Given this list of marker genes Fgfr3, Hes5 (hes family bHLH transcription factor 5), Adgrv1 (adhesion G protein-coupled receptor V1), Bmp4, Strc, Gfi1, Cdh23, Grxcr1, Pjvk, Whrn, Alg10b, Ush1c, Pafah1b1, Ntrk2, Atoh1, Gabrb3, Jag1, Elmod3, Hes1, Trip11, Triobp, Rbpj, Pcdh15, Gabrb2, Atp8b1, Grxcr2, Rac1, Atp2b2, Tecta, Tsku, Minar2 (membrane integral NOTCH2 associated receptor 2), Myo6, Ntf5, Cux1, Mycn, Kif3a, Fgfr1, Clrn1, Lhfpl5, Hey2, Kcnq1, Pls1, Dll1, Mcoln3, Clic5, Ptprq, Fzd2, Nherf1, Slc4a7, Cthrc1, Fat4, Otog, Sec24b, Esrp1, Ift27, Sdc4, Cecr2, Ripor2, Ntrk3, Mks1 (NCBI Gene Id 380718), Dicer1, Fgf2, Slc44a4, Tprn, Ift20, Ift88, Scrib, Ush2a, Gabra5, Slitrk6, Mycl, Ttc8, Tmem132e, Fgf20, Wdpcp, Notch1, Kcnma1, Naglu, Alms1, Gsdme, Sod1, Ntf3, Myo3a, Pou4f3, Rest, Myo7a, Tomt, Clrn2, Hey1 (NCBI Gene Id 99610), Pdzd7, Vangl2, Ankrd24, Mir96, Myo3b, Jag2, Ntrk1, Bdnf, Tmc1 (NCBI Gene Id 74462), Diaph3, Tshr, Ush1g, Otogl (otogelin-like), here is a description of the gene set: The process in which a relatively unspecialized cell acquires specialized features of a mechanoreceptor, a cell specialized to transduce mechanical stimuli and relay that information centrally in the nervous system. Mouse Gene Set: GOBP_MECHANORECEPTOR_DIFFERENTIATION species: Mus musculus